Given this list of marker genes SLCO1B3, here is a description of the gene set: Reactome Pathway: Defective SLCO1B3 causes hyperbilirubinemia, Rotor type (HBLRR) In the body, solute carrier organic anion transporter family member 1B3 (SLCO1B3) is expressed on the basolateral surfaces of hepatocytes and may play a role in the uptake of bilirubin (BIL), a breakdown product of heme that requires conjugation and excretion from the body. Defects in SLCO1B3 can cause hyperbilirubinemia, Rotor type (HBLRR; MIM:237450), an autosomal recessive form of primary conjugated hyperbilirubinemia. Mild jaundice, not associated with hemolysis, develops shortly after birth or in childhood (van de Steeg et al. 2012, Sticova & Jirsa 2013, Keppler 2014). studied in species Homo sapiens part of: SLC transporter disorders